Given this list of marker genes Lgr5, Ubc, Usp8, Igfals, Uba52rt, Znrf3, Rps27a, Rspo2, Rnf43, Lrp6, Ubb, Uba52, Fzd4, Fzd5, Rspo4 (NCBI Gene Id 77217), Fzd8, Wnt3a, Lrp5, Fzd6, Rspo1 (NCBI Gene Id 192199), Rspo3, here is a description of the gene set: Mouse Gene Set: REACTOME_REGULATION_OF_FZD_BY_UBIQUITINATION Regulation of FZD by ubiquitination species: Mus musculus